The following is a description of a gene set: Human Gene Set: SNAI1_TARGET_GENES species: Homo sapiens Genes containing one or more binding sites for (SNAI1) in their promoter regions (TSS -1000,+100 bp) as identified by GTRD version 20.06 ChIP-seq harmonization. from publication Yevshin I, Sharipov R, Kolmykov S, Kondrakhin Y, Kolpakov F (PMID 30445619), and this is the list of marker genes: SEPTIN9, PI4K2B, KLHL36, ATF2, UQCC6, CFAP20, SNX8, LAMA5, GRHL3, MIEF2, ZNF358, GLRX, TRAF4, MT-TE, CCDC146, NFE2L2, SEC23B, PRMT5, CIRBP, ZNF629, PCID2, ZNF687, YJU2, SET, RPL18A, MT-TV, ERAP1, NEDD9, ODC1, RBBP4, TRIM8-DT, SLC24A1, SNORD54, MT-RNR2, ATL1, LINC01939, ZNFX1, MTND1P15, MT-TD, OSGEPL1-AS1, INTS4, FAM229B, COL4A2, DUSP6, METTL2A (NCBI Gene Id 339175), MED4, SNRPA, SEMA4B, KIF20A, POLR1B, ACTR6, ENSG00000275765, INTS14, MT-RNR1, ENSG00000248994, MT-TF, C2orf15, VMAC, PRR27, MT-TS2, ULK3, MFAP1, LAPTM4A-DT, UACA, YAP1, CCDC103, CERNA3, FAM185BP, MGAT1, MT-CO3, GRHL2, ZNF233, G3BP1, PLCB4, EMX1, MAP3K11, CAPZA2, ZNF526, MT-TY, CYB5D1, SLC28A2-AS1, RNA5SP210, DDX18, WTAP, KCNQ1, CCT3, MCM3, MGRN1, BTF3L4, BROX, C12orf76, FOXP1-DT, H3-3B, PAXIP1, EEF1G, KSR2 (NCBI Gene Id 341537), ENTPD8, IGLV6-57, TUFT1, MIR4648, NDC1, OAS1, NFKBIA, TSACC, HNRNPL, SEL1L3, SHTN1, LARGE2, CCDC6, DEAF1, NELFA, UBE2M, AMZ2P1, LINC01596, ZNF225, SLC22A31, AIDA, SEC11C, NDUFA2, PLEC, SNORA80B, SYCE3, MT-TW, AHSA1, GOLT1A, PICK1, CAST, NME1-NME2, TMEM87B, PRPSAP2 (phosphoribosyl pyrophosphate synthetase associated protein 2), LINC02901, DMPK, COQ7-DT, MT-ND1, BANP, METTL2B, GANC, HSD17B11, CFAP418, MAP4K5, HOMER1 (homer scaffold protein 1), UBXN2B, NIPAL3, KLHDC4, CAPN10, ATP6V0E2, MTCO3P12, CUL4A, WSCD1, SEPTIN7P14, MT-CO1, ENSG00000215156 (novel protein), MRPL43, TMEM165, KIF18A, FNTB, ESRP2, MAPRE2, PPP3CB-AS1, GNAL, GABPB1-AS1, AKT1S1, NR1H3, EXOC3-AS1, NFATC4, MED16, SRBD1, ASTL, JADE1, MARCHF9, TPI1P2, AAAS, TXNDC12, WRAP53 (NCBI Gene Id 55135), GSE1, DGKA, ADCK5, PPIG, EHD1, PPP3CB (NCBI Gene Id 5532), MIR3621, EIF3E, GTF2IP12, MIR7-3, NDUFV2, SSBP1, MRPL57, PLPP5 (NCBI Gene Id 84513), MAN2A2, TTC13, HAUS5, ACTMAP (NCBI Gene Id 284325), UBP1, MST1P2 (macrophage stimulating 1 pseudogene 2), MT-ATP8, P3H4, JUP (junction plakoglobin), STX16 (syntaxin 16), ZRANB3 (zinc finger RANBP2-type containing 3), RAB11A, IL15RA, ENSG00000247131, PITPNM1 (NCBI Gene Id 9600), TOB1, MIR933, POC5, PGAM5, TMC4, MAL2, ZNF223, CRELD1, MT-ND4, ZC3H10, RPS6, ACLY, ME3, PAWR, FGD4, C1orf174, GCA, PPP1R12A-AS2, DUX4L18, MRPL38, PGD, MCM7, ZFYVE28, PRAMEF31P, MIR4531, SHC2, ROCK1P1, ASCC2, MT-TT, FKBP10, MT-TR (mitochondrially encoded tRNA-Arg (CGN), NCBI Gene Id 4573), TRMT44, NOSIP, LNX1 (NCBI Gene Id 93989), MSMP, ADIRF, BRD8, DUX4L9, TTC6, ZNF225-AS1, HEXA-AS1, CSNK2A1, TPCN1, IFNAR1 (NCBI Gene Id 3454), TDRKH-AS1, LINC02320, SCAMP2, ARRDC3, WDR11, EIF2S2, SKA3, TMEM125 (transmembrane protein 125), EFTUD2, SEC22B, MIR8078, PCLAF (PCNA clamp associated factor), HEXIM1, ZSCAN25, MT-TN, TIMM44, ZNF775, BOP1, SLC30A10 (solute carrier family 30 member 10), LINC02142, TSPAN31 (NCBI Gene Id 6302), METTL15, ACOX3, ATAD2, STRBP, TBC1D17, DUX4, TBC1D19, TM7SF3, ABHD18 (NCBI Gene Id 80167), SMAD3, LRIG2, MT-TQ, HIGD2A, NOP16, HMBOX1, TFRC, DEDD2, C11orf52, EPB41L5, SNX16, LINC00957, MCCC1, TACC3, SPANXB1, MT-TH, DDX5, GUSBP18, PRKCH, ODC1-DT, SIN3A, RABGGTB, SMG9, GABPB1, NOMO3, STPG1, PTBP1, ATP5PB, EIF3FP1, FAM174A-DT, BSPRY, FA2H, ADIRF-AS1, ZBTB8OS, PGM3, WDR77, LINC01342, IL17C, RPS20, ITGA3, KIAA1671, NDUFC1, SULT2B1, SNORD12C, PRR15L, MTND5P11, MOCS2-DT, ZFAS1, TSGA10, HEXA, TMEM129, TMEM87A, CNBD2 (NCBI Gene Id 140894), TWNK, PCDH12, IL15, WEE2-AS1, DDR1, MRPL1, EDC3, INTS9, NPEPPS, TMEM184A, SFT2D2, RASA4CP, ANKHD1-EIF4EBP3, DSTYK, KANK3, GBA1, ANKHD1, DPH7, PRMT5-DT, GRHL2-DT, PIM1, ADAMTS6, VIPAS39, PCGF1, FRG1DP, FAM174A, CDRT15P3, SNORD45A, SERINC4, USP17L24, STX16-NPEPL1, LINC03060, WDR11-DT, ESPN (NCBI Gene Id 83715), ZSCAN16 (NCBI Gene Id 80345), NDUFA11, GPR107, LAPTM4A, MT-ATP6, STAT6, VPS13C, POU6F1, RNA5SP162, CCAR2 (cell cycle and apoptosis regulator 2), USP48, NFKB1, PICART1, PDE4C, TOR1AIP1 (torsin 1A interacting protein 1), PRRG2, POLR1H, CFAP99 (NCBI Gene Id 648970), ARV1, STARD10, NPEPPSP1, VPS26C, ABR, WASH3P, ZNF785 (zinc finger protein 785), SYT8, FBP1, INTS12, PRSS37, USP17L16P, APH1B, TRIM8, ENSG00000206977, KRR1, NASP, PYM1 (PYM homolog 1, exon junction complex associated factor), MFSD8, MUC6, ENSG00000200288, MT-ND4L, MT-CYB, C17orf75, AGPS, ENSG00000213963, DEGS2, PPIB, CADPS2, RAB3IP, MFSD13A, IER5L (immediate early response 5 like), CHAC1, TJP2, CROCCP2, R3HDM1, RPL5, MIR7-3HG, KMT2A, PHF14, REPIN1 (replication initiator 1), FDPS, SCAND1, TMEM80, TNPO3, NME1, SSBP3P5, MYO5B, IFRD2, KDF1, TATDN2P2, MT-TA, EPS8L2 (NCBI Gene Id 64787), HCG14, SLC22A23, FAM187A, G3BP2, ITGB4, IK, LERFS, ZNF354B, MT-TL1, NAA60, BAG6, MT-ND5, ZNF749, FAM174B, TAF3, SELENOT, CEP95, ATG4D (NCBI Gene Id 84971), MBP, BCLAF1, SNAI1, C6orf52, ATP6V0E2-AS1, NUDT14, SCAI, OSGEPL1, FRMD5, MT-TK, CLDN7, ANKHD1-DT, RNF19A, LAMA3, TMEM101, CYP2D6 (cytochrome P450 family 2 subfamily D member 6), GSK3A, IQCD, TDRKH, MLLT3, PADI2, MT-TC, ACP2, EPG5, MT-ND6, ZNF133, COQ7, PSTK, UNC5B-AS1, LRIG2-DT, LINC01297, MIR375, SRD5A3-AS1, FOXP1, HSBP1L1, LLGL2, MT-TS1, POLR1HASP, ISG20, LFNG, PEX12, ZNF14, SMURF2P1, ENSG00000224090, RDH13, PALD1, MMP15, NDUFA9, HYPK, LSR, TRIP4, AGPAT3, NPDC1, GRB7, LCN15, KANK2, FOXA1, MAGOHB, MIR1302-3, MT-TL2, MTERF4, GSTCD, NOL4L, NAA38, NBPF1